The following is a description of a gene set: Human Gene Set: GOBP_SYMPATHETIC_NERVOUS_SYSTEM_DEVELOPMENT studied in species Homo sapiens The process whose specific outcome is the progression of the sympathetic nervous system over time, from its formation to the mature structure. The sympathetic nervous system is one of the two divisions of the vertebrate autonomic nervous system (the other being the parasympathetic nervous system). The sympathetic preganglionic neurons have their cell bodies in the thoracic and lumbar regions of the spinal cord and connect to the paravertebral chain of sympathetic ganglia. Innervate heart and blood vessels, sweat glands, viscera and the adrenal medulla. Most sympathetic neurons, but not all, use noradrenaline as a post-ganglionic neurotransmitter., and this is the list of marker genes: NF1, PHOX2A, PHOX2B, HAND2, GATA3 (GATA binding protein 3), NRP1, TP63, PLXNA4, FZD3, EDNRA, NRP2, GFRA3, TFAP2B, CTNNB1, ASCL1, SEMA3A, SOX11, SEMA3F, GDNF, INSM1, SOX4, NTRK1